The following is a description of a gene set: Genes predicted to be targets of miRBase v22 microRNA hsa-miR-8056 in miRDB v6.0 with MirTarget v4 prediction scores > 80 (high confidence targets). studied in species Homo sapiens Human Gene Set: MIR8056 from publication Chen Y, Wang X (PMID 31504780), and this is the list of marker genes: SPPL3, RYBP, SLC6A13, CSDE1, VAX1, LMO4, FMOD, SANBR, PDE4D, FBXO30, ERBB3, DAZ1, KCTD16, DDHD2, XRRA1, DARS1, AREL1, SLC6A14, TPM4, ATPAF2, PPP4R3A, DPT (dermatopontin), ZNF442, SLC36A2, LYRM2, PABPC5, MRPS14, ACLY, RPS6KC1, PLCB1, ZNF74, SPMIP2, ZNF189, CPEB2, RORA, ZNF185, ZNF135, UNC5D, KCNMA1, RFC3, BLOC1S6, UPF2, DAZ2, PARG, DAZ3, YTHDC1, CHRNA5, HSDL2, SEMA6A (NCBI Gene Id 57556), PDZD2